Given this list of marker genes RIOX2, KDM2A, KDM7A, PHF8, KDM4C, KDM4A, KDM4B, KDM2B, KDM8, RIOX1, here is a description of the gene set: Human Gene Set: GOMF_HISTONE_H3K36_DEMETHYLASE_ACTIVITY Catalysis of the removal of a methyl group from a modified lysine residue at position 36 of the histone H3 protein. This is a dioxygenase reaction that is dependent on Fe(II) and 2-oxoglutarate. species: Homo sapiens